The following is a description of a gene set: Human Gene Set: GOBP_L_ASCORBIC_ACID_METABOLIC_PROCESS studied in species Homo sapiens The chemical reactions and pathways involving L-ascorbic acid, (2R)-2--4-hydroxy-5-oxo-2,5-dihydrofuran-3-olate; L-ascorbic acid is vitamin C and has co-factor and anti-oxidant activities in many species., and this is the list of marker genes: GCLC, ATP1A2, SLC23A2, SLC23A1, SELENON, ERO1A, CLSTN3, SLC2A3, SLC2A1, GSTO1, GSTO2